The following is a description of a gene set: species: Mus musculus Mouse Gene Set: GOBP_POSITIVE_REGULATION_OF_EXTRACELLULAR_MATRIX_DISASSEMBLY Any process that increases the rate, frequency or extent of extracellular matrix disassembly. Extracellular matrix disassembly is a process that results in the breakdown of the extracellular matrix., and this is the list of marker genes: Meltf, Clasp2, Pdpn, Carmil2, Fscn1, Il6, Clasp1, Ddr2, Sema5a, Tgfb2